The following is a description of a gene set: Functional abnormality of the middle ear Human Gene Set: HP_FUNCTIONAL_ABNORMALITY_OF_THE_MIDDLE_EAR studied in species Homo sapiens An abnormality of the function of the middle ear., and this is the list of marker genes: PRRX1, DIAPH3, DNAAF3, SNRPB, RBP3, BEST1, CRB1, AHR, HLA-DRB1, RPE65, CDH1, HOXA2, DNAAF4, SLC7A14, DNAH5, AMER1, ENPP1, DVL1, TMEM231, TBX1, PDE6A, SNF8, OFD1, DNAAF11, CREB3L1, SLC25A24, FAM20C, SPAG1, DCHS1, ARSL, CFAP418, BMP4, ANKH, ODAD2, DLG1, STAC3, ZMPSTE24, DNAAF6, HDAC8, SRCAP, CCDC40, SDHC, CHD7, FSCN2, RP2, CLRN1, POLR1D, ODAD3, MYH3, ABCA4, BRD4 (bromodomain containing 4), RET, FRAS1, ZNF699, IQSEC2 (IQ motif and Sec7 domain ArfGEF 2, NCBI Gene Id 4382), ARHGAP29, ERCC8, FLII, CCBE1, FANCF, TMEM216, TCOF1, EXT1, ERF, VARS1, SMCHD1, TELO2, GNPTAB, KDM6A, ARHGEF18, CRX, TTC8, DHDDS, SALL4, CCDC39, FAT4, SH2B1, CREBBP, PRPF4, PDGFRA, KIZ, MAK, FOXL1, SOST, KIAA0753, CERKL, SF3B4, GDF6, ARL6, JMJD1C, GRIP1, TTC12, OTOF, ZNF408, CA4, NOG, PRORP, KIAA1549, GJB6, NEK2, MMP23B, GMNN, ARL3, FGFR2, PDE6D, DNAAF5, EYA1, TAF4, NRL, HIRA, RP1, PRCD, IGBP1, DEAF1, TXNL4A, MSX1, FANCI, IRF6, FGFRL1, SEC24C, BBS1, AGBL5, B3GLCT, SDHD, SCAPER, EP300, PDPN, ARID2 (AT-rich interaction domain 2), SPEF2, ALX3, SPEN, CNOT3, RSPH9, COL1A2, SKI, VHL, POLR1C, SETD2, SMC1A, ABCC6, PCGF2, POLR1B, REEP6, COL11A2, RPGR, FAM161A, SDHA, PCARE, AHI1, NME5, SLC25A11, HDAC4, CDHR1, CFAP74, DNAH9, RDH12, RAD21, IFT88, ERCC6 (ERCC excision repair 6, chromatin remodeling factor), FGFR3, CTBP1, TRPS1, DNAJB13, UBB, GJA1, DNMT3A, MASP1, CDK5RAP2, NEK10, FAM149B1, PAX1, LUZP1, PRPH2, PSMD12, CTSK, SLC35C1, RSPH1, SMC3, ZFX, CHRNG, APC2, TUB (NCBI Gene Id 7275), GSC, RHO, PRPF6, NECTIN1, TWIST1, CCNO, DNAAF1, TP63, NEK1 (NIMA related kinase 1), SF3B2, AFF4, TSR2, CFAP221, DDR2, ZNF513, IMPG1, COL2A1, DLST, STK36, SGMS2, GAS8, CDCA7, IMPG2, ANKRD11, EIF5A, AMMECR1, PROM1, CNGB1, FGF9, GDF5, NSD1, RAI1, FKBP14, DNAL1, TMEM67, CASZ1, SOX9, SIX1, OSTM1, CACNA1B, MAX, CC2D2A, TBX22, NOTCH3, LRP5, FLNB, GALNT2, SP7, LRRC56, LMNA, PRPF8, GJB2, HSPG2, MAN2B1, KLHL7, NR2E3, MDH2, HAX1, FGF10, IDH3A, CDH11, HLA-B, DNAI2, IFT172, HYDIN, ODAD4 (outer dynein arm docking complex subunit 4), SDHB, CTNND1, TAF6, PDE6G, EDN1, ZMYND10, FBXW7, RP9, NOTCH2NLC, MPDU1, GAS2L2, COBLL1, NSD2, GUCA1B, POMGNT1, RERE, MAP3K7, PGM3, GRHL3, RGR, PORCN, BMP2, ARHGEF38, IL11RA, KCNAB2, UBE4B, LONP1, PTPN22, ZNF469, FREM2, TFAP2A, BPTF, SNRNP200, DNAI1, EYS, PDE6B, DNAH1, RREB1, GP1BB, HGSNAT, DNAH11, PRKCZ, NME8, SEMA4A, USH2A, RPS28, COMT, B3GALT6, RP1L1, GABRD, FOXJ1, EPAS1, LETM1, MEOX1, DRC1, DNAAF2, RLBP1, KMT2D, EFTUD2, RIC1, KIF7, RAB23, DHODH, KIF1B, NOTCH2, FBN1, ROBO1, MERTK, POR, RSPH4A, TNFRSF11A (TNF receptor superfamily member 11a), RECQL4, PRDM5, CFAP298, HNRNPK, SPATA7, COG1, NFIX, RSPH3, TMEM127, RPS23, NF1, PRPF3, ACVR1, NIPBL, LRAT, CNOT1, TSHZ1, DHX38 (NCBI Gene Id 9785), MYCN (NCBI Gene Id 53360), CA2, TCTN3, PRPF31, FH, TOPORS, RPS26, DLX4, ZBTB20, SDHAF2, P4HA2, IDS, PRDM16, ODAD1, PIK3C2A, TULP1, SIX5, ALX1, AIFM1, CPLX1, POU3F4, IDH3B, SAG, ARL2BP, ADAMTS3, ELMOD3, PIGL, CPLANE1, ARVCF, CFAP300 (NCBI Gene Id 85016, cilia and flagella associated protein 300), CNGA1, FLNA, EDNRA, UFD1, ELMO2, IFT140 (intraflagellar transport 140), MCIDAS, ROM1, IMPDH1, BBS2 (Bardet-Biedl syndrome 2)